Given this list of marker genes ASS1, SLC25A15, SIRT5, NAGS (NCBI Gene Id 162417), TP53, SLC25A2, ASL, ARG2, ARG1, CPS1, NMRAL1, OTC, here is a description of the gene set: part of: Metabolism of amino acids and derivatives studied in species Homo sapiens The urea cycle yields urea, the major form in which excess nitrogen is excreted from the human body, and the amino acid arginine. It consists of four reactions: that of ornithine and carbamoyl phosphate to form citrulline, of citrulline and aspartate to form argininosuccinate, the cleavage of argininosuccinate to yield fumarate and arginine, and the cleavage of arginine to yield urea and re-form ornithine. The carbamoyl phosphate consumed in this cycle is synthesized in the mitochondria from bicarbonate and ammonia, and this synthesis in turn is dependent on the presence of N-acetylglutamate, which allosterically activates carbamoyl synthetase I enzyme. The synthesis of N-acetylglutamate is stimulated by high levels of arginine. Increased levels of free amino acids, indicated by elevated arginine levels, thus stimulate urea synthesis.<p>Two enzymes catalyze the hydrolysis of arginine to yield ornithine and urea. Cytosolic ARG1 is the canonical urea cycle enzyme. Mitochondrial ARG2 likewise catalyzes urea production from arginine and may have a substantial sparing effect in patients lacking ARG1 enzyme, so its reaction is annotated here although the role of ARG2 under normal physiological conditions remains unclear. Reactome Pathway: Urea cycle